Given this list of marker genes ELMO3, KCNN1, NEDD4, GRIN2B, TSC1, FBXO40, JUN, FGF5, ZNF385B, GNG11, CACNA2D3, HDAC9 (histone deacetylase 9), ITGB3BP, PAK6, MBNL2, ZFPM2, FGF6, TSPEAR, CRTAP, BMP4, IL17B, PRICKLE2, SP6, KLHL20, PPP1R16B, WFDC1, MARCHF1, BEGAIN, ARHGEF15, UBXN10, PPP2R2B, S1PR1, PENK (proenkephalin), COL13A1 (collagen type XIII alpha 1 chain), MAS1, ARHGEF37, DBNDD2, EHD1, FOS (NCBI Gene Id 2353), MYL1, KLHL40 (kelch like family member 40), CSRNP3, PTCHD4, SCML1, SLCO2A1, KCNJ9, CA7, DDX6 (NCBI Gene Id 1656), ITGA7, EYA1, TMEM108, GET4, MYL2, CDC42EP3, SLC26A9 (NCBI Gene Id 65013), CELF4, STARD13, ZNF516-DT, MYL6B, SLC3A1, MTF1, KRT83, ENO3, LMCD1, AICDA, DLL4, LUZP1, TPM2, ZNF362, SMPX, MAP2K5, MYH4, TSC22D1, NAT8L, MAB21L2, AKAP12, OR8B8, CCDC91, COLQ, ZIC4, GTF3C3, MYH6, NFIX, SMARCA1 (NCBI Gene Id 6594), KRT222, GPC4, LYN, ARPP21, HAS2, NDP, RIPOR1, SLC13A1, ZBTB18, GATA4, JPH2, SMYD1, CKMT2, GRK7, SYNPO2L, HS3ST5, SLITRK1, NR4A1, PAQR9, HOXB5, SSPN, SOX2 (SRY-box transcription factor 2), ART5, USP47, CAPN1, ZNF436, DYRK2, CKM, CASQ2, PHOSPHO1, ZC3H11A, HAPLN1, EP300, TIMP2, NCAN, TNNC1, KCNK9, MBNL1, MPC2, DKK1 (NCBI Gene Id 22943), SLC44A1, ZNF436-AS1, SOX14 (NCBI Gene Id 8403), PDLIM1, AFF4, ZNF143, HDAC7, DMD, GEN1, TBC1D16, FOXN3, EPHA7, SSH3, DNAJA2, MYO9A, TNNI3K, ATL2, here is a description of the gene set: Human Gene Set: HMEF2_Q6 species: Homo sapiens Genes having at least one occurrence of the motif SKYTAAAAATAACYCH in the regions spanning 4 kb centered on their transcription starting sites. This matches the transcription factor binding site V$HMEF2_Q6 (v7.4 TRANSFAC).